Given this list of marker genes HSDL1, MTA2, OGT, ATP8A2, PRKAR1A, QKI, GUCY1B1, PYURF, CDH4, CREBZF, ZNF267, SLC22A23, GAN, FAM185A, COL26A1, PIGY, MIGA1, WDR44, ZNF460, METTL13, TANC2, GDPD4, CARF, USP24, RBAK, EPGN, STOX2, ANAPC15, LCLAT1, SANBR, BASP1, NRAS, MYH9, AFF1, NEK9, ZBTB26, PGAM1, KIF3B, AMZ2, ZNF268, KCNN3, INTS9 (NCBI Gene Id 55756), CNOT6L, BAZ2B, ANKRD13A, DCANP1, TACC1, ODF2, CBLN1, HEATR5B, ICA1L, TUBGCP3, PGAM4, IGF1, MED1, here is a description of the gene set: species: Homo sapiens from publication Chen Y, Wang X (PMID 31504780) Genes predicted to be targets of miRBase v22 microRNA hsa-miR-483-3p in miRDB v6.0 with MirTarget v4 prediction scores > 80 (high confidence targets). Human Gene Set: MIR483_3P